The following is a description of a gene set: studied in species Homo sapiens Abnormal movements of the upper extremities. Stereotypic upper-extremity movements Human Gene Set: HP_STEREOTYPIC_UPPER_EXTREMITY_MOVEMENTS, and this is the list of marker genes: TRAPPC9, SLC4A10, MECP2, IQSEC2 (NCBI Gene Id 4382), FMR1, DHPS, NEXMIF, GABBR2, SYNGAP1, BCL11A, CASK, TAF4, PDZD8, ASXL3, CIC, H4C5, DHX30, HECW2, UBE3A, DYRK1A, PUM1, CDKL5, NAA20, TRAPPC6B, NOVA2, GRIA2, HERC2, CUX2, CNTNAP2, CDK19, PRKAR1B (protein kinase cAMP-dependent type I regulatory subunit beta), LMNB1, MBD5, CELF2, ZBTB18, HNRNPH2, LARP7, GRIK2, NTNG1 (NCBI Gene Id 22854), SATB1, SMC1A, CHD8, CCNK, GRIN1, MGAT2, AP1S2, NACC1, GRIN2A, AFF2, CACNA1B, GNAI1, VAMP2, CSNK2A1, KCNB1, HDAC4, KMT5B, OCA2